Given this list of marker genes Optn, Cep72, Ccnb1, Tubb4a, Rab8a, Clasp1, Tubb4b, Haus7, Haus8, Tuba4a, Prkaca, Cep131, Csnk1e, Ninl, Nedd1, Cep63, Ywhae, Dctn1, Cep41, Haus5, Actr1a, Rps27a, Sfi1, Cul1, Cep135, Cep43, Cep290, Cep152, Cenpj, Nde1, Tuba1a, Ajuba, Bora, Cep192, Ubb, Plk1, Prkar2b, Cep57, Cdk1, Sdccag8, Haus1, Dynll1 (NCBI Gene Id 56455), here is a description of the gene set: electronically inferred by orthology from the curated human pathway part of: G2/M Transition Reactome Pathway: Regulation of PLK1 Activity at G2/M Transition This event has been computationally inferred from an event that has been demonstrated in another species.<p>The inference is based on the homology mapping from PANTHER. Briefly, reactions for which all involved PhysicalEntities (in input, output and catalyst) have a mapped orthologue/paralogue (for complexes at least 75% of components must have a mapping) are inferred to the other species. studied in species Mus musculus